The following is a description of a gene set: Genes having at least one occurrence of the highly conserved motif M30 YGCGYRCGC in the regions spanning 4 kb centered on their transcription starting sites. The motif does not match any known transcription factor binding site. Comprehensive identification of all functional elements encoded in the human genome is a fundamental need in biomedical research. Here, we present a comparative analysis of the human, mouse, rat and dog genomes to create a systematic catalogue of common regulatory motifs in promoters and 3' untranslated regions (3' UTRs). The promoter analysis yields 174 candidate motifs, including most previously known transcription-factor binding sites and 105 new motifs. The 3'-UTR analysis yields 106 motifs likely to be involved in post-transcriptional regulation. Nearly one-half are associated with microRNAs (miRNAs), leading to the discovery of many new miRNA genes and their likely target genes. Our results suggest that previous estimates of the number of human miRNA genes were low, and that miRNAs regulate at least 20% of human genes. The overall results provide a systematic view of gene regulation in the human, which will be refined as additional mammalian genomes become available. species: Homo sapiens from publication Xie X, Lu J, Kulbokas EJ, Golub TR, Mootha V, Lindblad-Toh K, Lander ES, Kellis M (PMID 15735639) Human Gene Set: YGCGYRCGC_UNKNOWN, and this is the list of marker genes: HNRNPR, RPP38-DT, TIGD6, MTRFR, HOXA4, ZZZ3, VRK3, PGM2L1, MAGI1, KLF13, HILPDA, SLITRK4, SLC25A37, GNAS, ATG12, ELP1, KIF7, GBX2, PENK, ZNF524, BCL9, MTMR3, ID3, PHAF1, GPD1L, NRGN, USP37, CYP1B1, UROD, TMEM179, VKORC1L1, PRKAG2, FAM120C, DLGAP4, ST8SIA1, RNF149, ZNF521, KDM4C, TTC9C, ADAM12, PIM2, SLC25A11, RPS4X, CALM3, EN1, ADO, NEURL1, ZDHHC14, MMP16, TMEM38B, SEMA6A (NCBI Gene Id 57556), CDON, MECP2, SYNCRIP, TFAP4, KDM1A, ZFY, PLOD3, MEPCE, GPAT4, PEX5L, PALB2, GEMIN4, NCAPD3, SMG6, ABCE1, IMMP2L, SLC25A12, RNF167, CTDSPL, ST8SIA2, RBKS, PAQR4, CDK5R1, PDS5B, CREBZF, RAB6A, MAZ, PKMYT1, PGRMC2, PRKAR2A, SGSM3, POP7, CDK16, NR2F2, TADA2A, FHOD1 (NCBI Gene Id 29109), MAP3K11, RNFT1, PATZ1, MAF, DNAAF1, C17orf58, DDIT3, BAG6, GSE1, ATP2A2, FAM133B, SERP1, TRIB2, TRIM8 (tripartite motif containing 8), PDE7A, RNF38, BICDL1, ATP13A1, FOXO4, NR2C2, CACUL1, DIAPH1, PACRG, METAP1D, AP3S1, NDUFA13, SLC9A5, PPP3CC, INHBB, SLC12A5, DCTN5, EIF3D, L1CAM, EDEM3, BABAM2, CCS, ASIC1, CCDC107, ESCO1, TPR (translocated promoter region, nuclear basket protein), PCNT, HSDL1, SGF29, XPO5, GOLGA2, HNRNPA3, C2orf15, CFL1, PALS1, FMR1, TAOK1, RNF123, NPAS2, PPARGC1B, STX12, PSMD2, ANAPC10, SORCS3, ERP29, LENG8, SPTAN1, SRRM4, TMEM108, RGS7 (NCBI Gene Id 6000), HNRNPL, CCDC106 (NCBI Gene Id 29903), TRIM33, RETREG3, ARRB2, P4HTM, HNRNPD, SPINK5, ACACA, BCLAF1, FUT8, C1orf43, IMMT, ATP5MC2, MTHFD2, FBXW9, RPP38, SHH, TMEM132E-DT, SOX12, SMTNL2, SPRY4, CCDC87, RAB33A, DNAJA1, TMEM132E, KCNN1, ZCWPW1, GABRA4 (gamma-aminobutyric acid type A receptor subunit alpha4), ROM1, TCTA (T cell leukemia translocation altered), SKP2, C9orf40, RBBP4, FYTTD1, MLLT10, ZFP91, PSD, SRR, POU4F1, GTF2I (general transcription factor IIi), AKAP8, DLL1, CHD4, ZNF711, EXOG, CA10, CRY1, AAMP, PDP2, SLC16A6, HNRNPDL, SPINT2, GOPC, HNRNPAB, PPM1A, HOXA1, MNT, PRR7, RPS6KA5, CD320, POLH, PRKN, RAB10, ACSL4, SLC35B3, PNKD (NCBI Gene Id 87830), HOOK3 (hook microtubule tethering protein 3), KCNC1, DCTN4 (dynactin subunit 4), TBC1D32, ZMYM4, LRFN5 (leucine rich repeat and fibronectin type III domain containing 5), TNKS2, ALKBH5, PDCD2L, RBFOX1 (NCBI Gene Id 54715), FAM98A, PPP4R4, KAZALD1, UBE2S, ARL17A, TMEM116, KANSL3, RRAS, CKS2, SIX1, JPH4, LPCAT3, MST1, TFRC, COL25A1, SELENOI, KCNS2 (NCBI Gene Id 57457), FUS, C2CD2L, MAPT, TUBG1, POLR2B, ABHD15, NEUROD1, NEK8, CCNE1, MLX, CNOT9, YWHAE (NCBI Gene Id 7531), H1-10, TP53I13, RUNX1T1, MRPL14, SRSF6 (serine and arginine rich splicing factor 6), C21orf58, PHYHIPL, VEGFA, TSGA10, TEX264, UBTF (upstream binding transcription factor, NCBI Gene Id 7343), PUF60, ZBTB8OS, GTF2A1, HIC2, RAVER1, RILPL1, ANP32A, WAC, ASCL1, ABITRAM, PLEKHA1, PHF21B, MSL2 (NCBI Gene Id 55167), STARD10, PTGES3 (NCBI Gene Id 10728), NIPA2, ZGRF1, ULK2, KICS2, NAGK, NOA1, PCBP2, KANSL1L, KDM2A, EID1, SERBP1, RNF170, AATF, EML3, U2AF2, RNF207, SELENOF, ZIC2, GALNT17, ODR4, PMP22, HS2ST1, FIZ1, TSSK6, RHOA, MED26, HNRNPH1, PBRM1, POU2F1, MEIS2, EIF2A, VPS26B, NUDT3, MRPL45, HIBADH, TIAM1, TIMELESS, TIGD2, SF1, PPM1E, NXPH3, RPRD2, ZNHIT1